The following is a description of a gene set: Erythroid hypoplasia Decreased count of erythroid precursor cells, that is, erythroid lineage cells in the bone marrow. studied in species Homo sapiens Human Gene Set: HP_ERYTHROID_HYPOPLASIA, and this is the list of marker genes: RPL35A, RPS24, TSR2 (TSR2 ribosome maturation factor), RPS19, RPL9, TET2, ADA2 (NCBI Gene Id 51816), RPS14, RPL8, HEATR3, RPL26, TP53, RPL15, GATA1, RPS29, RPS15A, RPL11, RPL18, TCN2, RPS28, RPL5, RPL35, G6PC3, RPS20, RPS10, RPS26, RPS7, RPS27, RPL27, RPS17, RPL31